Given this list of marker genes Inppl1, Inpp5e, Inpp5k, Inpp5d, Inpp5j, Fig4, Ptprq, Ocrl, here is a description of the gene set: Mouse Gene Set: GOMF_PHOSPHATIDYLINOSITOL_3_4_5_TRISPHOSPHATE_5_PHOSPHATASE_ACTIVITY 1,2-diacyl-sn-glycero-3-phospho-(1D-myo-inositol-3,4,5-trisphosphate) + H2O = 1,2-diacyl-sn-glycero-3-phospho-(1D-myo-inositol-3,4-bisphosphate) + phosphate. species: Mus musculus